The following is a description of a gene set: from publication Chen Y, Wang X (PMID 31504780) Genes predicted to be targets of miRBase v22 microRNA mmu_miR_770_3p in miRDB v6.0 with MirTarget v4 prediction scores > 80 (high confidence targets). studied in species Mus musculus Mouse Gene Set: MIR_770_3P, and this is the list of marker genes: Aicda, Gbp4, Jam2, Jade1, Mcc, Atp11b, Zmiz2, Qsox1 (quiescin Q6 sulfhydryl oxidase 1), Pip4k2a, Klk4, Lrit1, Ifi203 (interferon activated gene 203), Plekhg1, Clip3, Rtp4, Dock5, Dennd5a, Thbs1, Taf2, Idh3a, Plin3, Scoc, Glt8d2, Gpatch2l, Sema4b, Epha8, Slc25a45, Opn4, Ercc4, Shroom1, Tmc8